The following is a description of a gene set: Genes down-regulated in peripheral blood monocytes (PBMC): healthy donors versus patients with HCV infection. from publication Bolen CR, Robek MD, Brodsky L, Schulz V, Lim JK, Taylor MW, Kleinstein SH (PMID 23067362) studied in species Homo sapiens This study characterizes the effects of chronic Hepatitis C virus (HCV) infection on gene expression by analyzing blood samples from 10 treatment-naive HCV patients and 6 healthy volunteers. Differential expression analysis of microarray data from peripheral blood mononuclear cells (PBMCs) identified a 136 gene signature, including genes elevated in infected individuals. Most of the up-regulated genes were associated with interferon (IFN) activity (including members of the OAS and MX families, ISG15 and IRF7), suggesting an ongoing immune response. This HCV signature was also found to be consistently enriched in many other viral infection and vaccination datasets. Validation of these genes was carried out using a second cohort composed of 5 HCV patients and 5 healthy volunteers, confirming the up-regulation of the IFN signature. In summary, this is the first study to directly compare blood transcriptional profiles from HCV patients with healthy controls. The results show that chronic HCV infection has a pronounced effect on gene expression in PBMCs of infected individuals, and significantly elevates the expression of a subset of interferon-stimulated genes. Human Gene Set: GSE40184_HEALTHY_VS_HCV_INFECTED_DONOR_PBMC_DN, and this is the list of marker genes: GPC5, ZMAT2, EIF3F, ACADL, SNF8, TESC, IL2RA, UBE2Q1, ZMAT5, FAAP20, EPB41, ETV5, SURF4, INF2, PPP3CC, ATG5, AAAS, FLT3LG, BHLHE40, PIM2, GPI, ARL15, JAZF1, EVL, APLP1, PGM2, ZNF740, TPI1, SLC39A8, AGFG2, RAMP1, BICD2, FKBP8, GLIPR2, FHIP1B, COASY, TSHZ1, PCIF1, PCYT2, BANF1, MRPS28, PRDM4, AKAP10, KATNB1, FKBP2, LCMT1, SGCB, IRAK2, MB21D2, TOR4A, ZNF652, MFSD10, OTUD5, SRI, AEBP2, MRPL23, TBX20, SEC23B (SEC23 homolog B, COPII coat complex component), TAP2, SLC45A4, UPF3A, SYTL2, MOB2, PITPNA, RELB, SHISA2, BICDL1, CCDC102A, YIPF3, DYM (NCBI Gene Id 54808), GNG2 (NCBI Gene Id 54331), DMRT1, ATP5MC1, ACAP1, MYO1G, GLDC, IFNG, TRIM67, DNAJC4, UBE2M, DDX42, QPCT, RDX, CD4, ART5, GNPTG, CIAPIN1, ICAM5, RWDD1, NRAS, ATP5F1E, ZNF687, ATP2B1, IL18RAP (interleukin 18 receptor accessory protein), FURIN, WRN, ITGB3, GRINA, PLAGL2, S100A6, PRDM1, SMURF1, PYGL, UPF1, RCBTB2, MYLK3, LGALS3BP, SLC35A4 (solute carrier family 35 member A4), TECPR1, DNAJC15, ARID5A (NCBI Gene Id 10865), KLRD1, TNNC1, SLC52A3, CCDC12, GABARAPL1, MED10, PIP5K1A, ATP6V0A2, C15orf48, SERPINB1, GCNT2, NRBP1, MLF2, CHADL, SH2B1, BYSL, KANSL1, TNFSF10, CREB3L2, DENND4C, ATP5MG, ABI3, SDC4, ZNF76, CAPG, KCNK7, ANAPC2, DLGAP5, UXS1, WNK1, NUCB1, TP53I13 (NCBI Gene Id 90313), POLR2I, MICAL1, FBXW4, WDFY1, ASB2, OR2T33, GPC1, GPBP1L1, HS3ST3B1, DDOST, RABGAP1L, FASTK, UGT8, RIOK1, TUT1, NDUFS3, TPGS1, FOXB1, SRGN, FAM13C (NCBI Gene Id 220965), L1CAM, ELOF1 (elongation factor 1), ZMYND8, SNCAIP, TM2D2, CCDC124, SAYSD1, MSANTD3 (Myb/SANT DNA binding domain containing 3), LY6E, SLC12A7, STK24, PIEZO1, TEX2, DCLRE1C, F2R, ITGB7, OPTN, FAM110A, MAP4K1, FYCO1, TBC1D9B, IL12RB2, SEC24D, SLC4A1, HACD2, ATG7, MAP2K2, ARPC4, MBD5, ADTRP, TES, TMED3, SH2D2A, CLINT1, ADM2, ALKBH7, IRAK3 (interleukin 1 receptor associated kinase 3)